The following is a description of a gene set: Any process involved in the maturation of a precursor Large SubUnit (LSU) ribosomal RNA (rRNA) molecule into a mature LSU-rRNA molecule from the pre-rRNA molecule originally produced as a tricistronic rRNA transcript that contains the Small Subunit (SSU) rRNA, 5.8S rRNA, and Large Subunit (LSU) in that order from 5' to 3' along the primary transcript. Human Gene Set: GOBP_MATURATION_OF_LSU_RRNA_FROM_TRICISTRONIC_RRNA_TRANSCRIPT_SSU_RRNA_5_8S_RRNA_LSU_RRNA studied in species Homo sapiens, and this is the list of marker genes: ZNHIT6, WDR12, NOL9, RBM34, ZNHIT3, URB1 (URB1 ribosome biogenesis homolog), RPL7, RPF2 (ribosome production factor 2 homolog), PAK1IP1, RPL7L1, FTSJ3, BOP1, DDX18, PES1, PPAN, RPL35, GTPBP4